Given this list of marker genes Gprc5a, Pkhd1, Cd86, Serpinb3d, Ace, Gprc5b, Hnrnpa2b1, Mir26a-2 (NCBI Gene Id 723962), Sdcbp, Fasl, Hspd1, Rap2b, Serpinb3b, Snx18, Aldoa, Fn1, Podxl, Aoc1, Sri, Anxa1, Mir451a, Gars1, Adam15, Mir106a, Rab11a, Plaa, Pkd1, Itga2b, Nsun2, Tmem98, Mir26b, Serpina5, Muc1, Myoc, Apoe, Egf, Cd63, Cd9, Anpep, Mir195a, Car4, Rab4a, Abcb6, Lamp2, Scnn1b, Gprc5d, Bhmt1b, Rbmx, Cd274, Mir16-2, Gprc5c, Clic1, Cubn, Prom1, Kif12, Hspa4, Slc9a3, Ago2, Bhmt, Ist1, Pmel, Acy1, Bag6, Qsox1, Serpinb3c (serine (or cysteine) peptidase inhibitor, clade B, member 3C), Icam1 (intercellular adhesion molecule 1), Aoc1l1, Ahnak, Mir17, Serpinb3a, Vasn (NCBI Gene Id 74207), Tfrc, Mir20a, Rab5b, Scnn1a, Anxa2, Epcip, Slc2a4, Rbmxl1, Alb, Naglu, Serpine1, Mir26a-1, Aqp2, Aqp1 (aquaporin 1), Mir16-1, Sord, Mir106b, Tsg101, Slc12a3, Hspa8, Ddx11, Xpnpep2, Slc26a4, Aoc1l3, Aoc1l2, Krt13, Pkd2, Actg1, Scnn1g, Ybx1, Pdcd6ip, Cd81 (NCBI Gene Id 12520), Ide, Slc12a1, Dicer1, Asah2 (NCBI Gene Id 54447), Cd47, Mir20b, here is a description of the gene set: studied in species Mus musculus Mouse Gene Set: GOCC_EXTRACELLULAR_EXOSOME A vesicle that is released into the extracellular region by fusion of the limiting endosomal membrane of a multivesicular body with the plasma membrane. Extracellular exosomes, also simply called exosomes, have a diameter of about 40-100 nm.